Given this list of marker genes CRH, CRY1, KCNQ1, TSPO, ECRG4, CRY2, TAC1, POMC, GAL, PTPN11, CRHR1, GALR1, SELENOM, GHRL, here is a description of the gene set: Human Gene Set: GOBP_GLUCOCORTICOID_SECRETION species: Homo sapiens The regulated release of any glucocorticoid hormone into the circulatory system. Glucocorticoids are a class of steroid hormones that regulate a variety of physiological processes, in particular control of the concentration of glucose in blood.